Given this list of marker genes CD247, IL18RAP, PTPN4, NPRL2, BTN3A3, ZAP70, MATK, ITGAL, RASGRP1, ARL4C, NKG7, GZMM, BTN3A2, SUN2, KLRB1, PRKCH, PLAAT4, TXK, CTSW, GZMA, RORA, KLRK1, MYBL1, SH2D1A, CD7, CD96, here is a description of the gene set: Human Gene Set: GNF2_ZAP70 Neighborhood of ZAP70 zeta-chain (TCR) associated protein kinase 70kDa in the GNF2 expression compendium studied in species Homo sapiens Neighborhood of ZAP70